Given this list of marker genes RYR2, AKAP1, C2orf88, SOX9, SPATC1L, CRYBG3, WASF1, AKAP12, AKAP11, AKAP8L, GSKIP, AKAP17A, AKAP6, LRRK2, DACT1, RARA, ARFGEF2, TDRD10, AKAP8 (NCBI Gene Id 10270), GRIA1, RDX (radixin), AKAP14, AKAP3 (NCBI Gene Id 10566), PRRC1, PKIA, EZR, KCNQ1, ARFGEF1, PJA2, PALM2AKAP2, CSK, AKAP10, AKAP4, AKAP13, AKAIN1 (A-kinase anchor inhibitor 1), ACBD3, RPS3, PRKAR2B, PRKAR2A, WASF3, DACT2, AKAP7, SPHKAP, GSK3A, PRKAR1A, DACT3, AKAP9, GSK3B, PRKACG, PRKAR1B, WASF2, MYRIP, PRKACA, AKAP5, SMO, here is a description of the gene set: Human Gene Set: GOMF_PROTEIN_KINASE_A_BINDING Binding to a protein kinase A. studied in species Homo sapiens